The following is a description of a gene set: species: Mus musculus Any process that modulates the frequency, rate or extent of miRNA catabolic process. Mouse Gene Set: GOBP_REGULATION_OF_MIRNA_CATABOLIC_PROCESS, and this is the list of marker genes: Zswim8, Lin28b, Qki, Zc3h12a, Tent2, Pnpt1